The following is a description of a gene set: species: Homo sapiens Human Gene Set: GOBP_REGULATION_OF_RECEPTOR_CATABOLIC_PROCESS Any process that modulates the frequency, rate or extent of receptor catabolic process., and this is the list of marker genes: LAPTM5, FURIN, HAMP, GIT1, MYLIP, PCSK9, ANXA2, ABCA2, PTPN1, DTX3L, ITCH, APOE, MTMR2